The following is a description of a gene set: Chromatin in the zygotic pronuclei transitions to a more open and accessible conformation by DNA demethylation and changes to histone modifications. As development proceeds through the cleavage stages to the blastocyst, chromatin continues to become more accessible until DNA methylation and a more restrictive chromatin conformation are re-established after implantation of the embryo in the uterus.<br>In the oocyte, H3K9me2 produced by EHMT2 (G9a, KMT1C) and H3K9me3 produced by SETDB1 (KMT1E) are transmitted to the female pronucleus of the zygote and protect maternal DNA from active demethylation (inferred from mouse zygotes in Zeng et al. 2019, reviewed in de Macedo et al. 2021). DPPA3 binds H3K9me2, preventing the 5-methylcytosine oxidase TET3 from being recruited to chromatin (inferred from mouse homologs in Nakamura et al. 2007, Wossidlo et al. 2011, Nakamura et al. 2012). DPPA3 also displaces UHRF1 from chromatin, preventing the maintenance DNA methylase DNMT1 from being recruited to chromatin and thus allowing passive DNA demethylation to occur in the female genome (inferred from mouse homologs in Funaki et al. 2014, Li et al. 2018, Du et al. 2019, Mulholland et al. 2020).<br>In the male pronucleus of the zygote, AICDA (AID) deaminates cytosine residues and long patch repair replaces the mismatches and adjacent 5-methylcytidine residues with cytidine. After this initial demethylation, TET3 is recruited to chromatin by METTL23 and STGP4 (GSE) (inferred from mouse homologs in Hatanaka et al. 2017) where it oxidizes remaining 5-methylcytidine to 5-hydroxymethylcytidine, which is removed by base excision repair and replaced with cytidine (inferred from mouse homologs in Gu et al. 2011, Iqbal et al. 2011, Wossidlo et al. 2011, Santos et al. 2013, Amouroux et al. 2016, Hatanaka et al. 2017).<br>The repressive mark H3K27me3 decreases in 2-cell embryos near developmentally related genes. The H3K27me3 demethylases KDM6B (inferred from bovine embryos in Chung et al. 2017, Canovas et al. 2012) and KDM6A (inferred from mouse embryos in Bai et al. 2019) appear to play a role in the decrease of H3K27me3, as downregulation of them impairs H3K27me3 loss, zygotic genome activation, and embryonic development. Embryonic development also requires H3K36me3, a permissive mark located in transcribed gene bodies that is produced in the oocyte by SETD2 (inferred from mouse embryos in Xu et al. 2019).<br>In mouse oocytes, H3K4me3 occurs in unusually broad regions that span genes Dahl et al. 2016, Zhang et al. 2016). These broad regions persist in the zygote and into the 2-cell stage. In the late 2-cell stage the more usual patterns of H3K4me3 are established as sharp peaks of H3K4me3 near the transcription start sites and stop sites of genes. The histone methyltransferase KMT2B is at least partly responsible for establishing the broad regions of H3K4me3 in the oocyte and the histone demethylases KDM5B and KDM5A remove the broad H3K4me3 in the late 2-cell stage embryo (inferred from mouse homologs in Dahl et al. 2016, reviewed in Eckerseley-Maslin et al. 2018).<br>In human oocytes and zygotes, however, broad regions of H3K4me3 are not observed across genes but are located across distal, CpG-rich domains which have partial DNA methylation. At the 8-cell stage, expression of KDM5B increases and the H3K4me3 at the distal domains is lost as zygotic genome activation occurs, suggesting a role for KDM5B in loss of H3K4me3. Reactome Pathway: Chromatin modifications during the maternal to zygotic transition (MZT) part of: Maternal to zygotic transition (MZT) species: Homo sapiens, and this is the list of marker genes: KDM6A (NCBI Gene Id 7403), H2BC11, H2AZ2, H2BC5, H2BC3, AICDA, H2BC4, KDM5B, H3C1, H2AC14, H2AC20, UHRF1, H2BC17, H2AJ, METTL23, STPG4 (NCBI Gene Id 285051), H2AC18, H2AC7, H2AC4, H4C1, H2AX, H3-3A, DPPA3, H2BC26, H3C15, H2BC13, KDM6B, H2BC12, TET3, H2BC12L, H2AB1, H2BC21, UNG, H2BC1, H2BC15, H2AC6, H2BC9, KDM5A, H2BC14